The following is a description of a gene set: studied in species Mus musculus Mouse Gene Set: REACTOME_CARNITINE_SHUTTLE Carnitine shuttle, and this is the list of marker genes: Ppard, Slc25a20, Acaca, Cpt2, Prkag2, Acacb, Mid1ip1 (Mid1 interacting protein 1 (gastrulation specific G12-like (zebrafish))), Rxra, Cpt1b, Prkab2, Thrsp, Cpt1a, Slc22a5, Prkaa2